The following is a description of a gene set: Binding to DNA segment that contains a bubble. A bubble occurs when DNA contains a region of unpaired, single-stranded DNA flanked on both sides by regions of paired, double-stranded DNA. Mouse Gene Set: GOMF_BUBBLE_DNA_BINDING species: Mus musculus, and this is the list of marker genes: Wrn, Ercc5, Hmgb1, Abl1, Neil3, Recql4, Blm